The following is a description of a gene set: species: Homo sapiens Human Gene Set: chr2q22, and this is the list of marker genes: SMC4P1, MTND5P24, TEX41, LINC01853, LINC01412, ZEB2-AS1, IDI1P1 (IDI1 pseudogene 1), RPL9P13, UBE2V1P14, LRRC57P1, HNMT, OTX2P2, MTCO2P5, LINC02993, RPL6P5, RNA5SP106, LINC01832, SNORA72, MTND2P19, GTDC1, MTCO3P5, MTND6P11, METAP2P1, ZEB2, ENSG00000226939, CXCR4, RNU6-692P, ARHGAP15, MTATP6P5, NXPH2, HNRNPKP2, LINC01966 (long intergenic non-protein coding RNA 1966), MTND4P22, MRPS18BP2, ARHGAP15-AS1, AHCYP4, MTCYBP11, RNF14P1, THSD7B, MTND3P9, SGCEP1, KYNU, YY1P2, RPL15P5, SFXN4P1, UBBP1, RNU6-715P, MTND4LP12, SPOPL-DT, RPS16P3, YWHAEP5, RNU6-904P, LRP1B, RRN3P4, PABPC1P2, ACVR2A, RNU6-1275P (NCBI Gene Id 106480122), RPL17P12, ENSG00000232377, MTCO1P44, LINC02631, RNU7-2P, ENSG00000303829, COPRSP1, MTND1P27, MIR7157, RN7SKP141, RN7SKP286, LINC01911, RNA5SP105, SPOPL, RN7SL283P